The following is a description of a gene set: species: Homo sapiens Human Gene Set: GOBP_MESODERM_MORPHOGENESIS The process in which the anatomical structures of the mesoderm are generated and organized., and this is the list of marker genes: POFUT2, ITGB1, ITGB3, TBX6, TAF10, KLF4, INHBA, PRKACA, AXIN1, ARMC5 (NCBI Gene Id 79798), NOG, WLS, ITGA2, TBX3, FOXF1, SMAD2, TWSG1, WNT3A, WNT5A, EYA1, SFRP2, HAND1, HOXA11, PAX2, WNT3, EYA2, BMPR1A, ITGA3 (NCBI Gene Id 4454), NCKAP1, GJA1, SRF, EOMES, MIR200C, ACVR1, ETV2, FOXC2, SCX, FGFR2, TAL1, BMPR2, GPI, NR4A3, TLX2, EXT2, TXNRD1, CRB2, EPB41L5, FGFR1, MESP1, MIR150, LEF1, PRKAR1A, FOXC1, ITGB4, SNAI1, APELA, MIR1-1, TRIM15, WNT11, TBX20, TBXT, SIX2, BMP7, SMAD1, MESP2, MSGN1, NODAL, EPHA2, TBX19 (T-box transcription factor 19), EXOC4, SMAD3, MIR145, DKK1 (dickkopf WNT signaling pathway inhibitor 1), NF2, KDM6B, ITGA8, BMP4, AHDC1, HMGA2